Given this list of marker genes Arr3 (NCBI Gene Id 170735), Prcd, Sag, Sptbn5, Ift20, here is a description of the gene set: Binding to an opsin, any of a group of hydrophobic, integral membrane glycoproteins located primarily in the disc membrane of rods or cones, involved in photoreception. Mouse Gene Set: GOMF_OPSIN_BINDING species: Mus musculus